The following is a description of a gene set: studied in species Homo sapiens Human Gene Set: GOMF_GLYCEROL_TRANSMEMBRANE_TRANSPORTER_ACTIVITY Enables the transfer of glycerol from one side of a membrane to the other. Glycerol is 1,2,3-propanetriol, a sweet, hygroscopic, viscous liquid, widely distributed in nature as a constituent of many lipids., and this is the list of marker genes: AQP1, AQP3, AQP7, AQP11, AQP10, AQP2, AQP7B, AQP9